The following is a description of a gene set: studied in species Mus musculus Mouse Gene Set: GOBP_L_HISTIDINE_TRANSMEMBRANE_TRANSPORT The directed movement of L-histidine across a membrane., and this is the list of marker genes: Slc38a3, Slc25a29, Slc66a1, Slc7a1, Slc38a5, Slc15a4